The following is a description of a gene set: from publication Chen Y, Wang X (PMID 31504780) species: Homo sapiens Genes predicted to be targets of miRBase v22 microRNA hsa-miR-4463 in miRDB v6.0 with MirTarget v4 prediction scores > 80 (high confidence targets). Human Gene Set: MIR4463, and this is the list of marker genes: ADSS2 (NCBI Gene Id 159), PRMT2, USP31, SELENON, LOXL2, AGO2, PITPNA, MAN1A2, XKR9, IREB2, SPC25, DDX55, MCCC2, CDC6, GLYAT, FGF5, ZSCAN21, GLIPR1L2, BRINP3, GOPC, NALF1, PALM2AKAP2, RIPK4, ASAP2, SLC9A4, GDPD2, AMOT, GAN, RPA1, ABCC9, CD8A, EAF1, EXOC6, SHISA9, OAS2, TCAF2, PDE8B, CTSV, GABRB1, VAMP1, KRR1, EBPL, KLF12, LPGAT1, EMB (NCBI Gene Id 133418), ZNF207, RPIA, PPP1R10, SURF4, TRIM4, LPP, ADIPOQ, ZNF264, CNOT2, ARRB1, OPHN1, ZNF785, KLRD1, CCDC97, MMRN2, MRPL35, RAD51B, BNC1, SLC8A1, TMEM203, KCNV1, PDHA1, CRK, ADNP, LRRC59, PDGFRL, CCDC86, DCDC2, G3BP2, RBFOX3, PARP15, TRIM33, KATNAL1, HIF1A, ZNF124, IGSF21, NRG3, ZNF326, CLDN1